Given this list of marker genes GDF15, BAX (BCL2 associated X, apoptosis regulator), B4GALT1, DDIT3, NUPR1 (NCBI Gene Id 26471), HYOU1, here is a description of the gene set: Genes down-regulated in synovial sarcoma samples with SYT-SSX fusions resulting from translocation of SS18 to one of the SSX genes. Chromosomal translocations are frequently associated with soft-tissue sarcomas. Fusion proteins generated by such translocations often play critical roles in tumorigenesis. Therefore, it is important to understand the function of the fusion protein to develop therapeutic interventions. The t(X;18)(p11.2;q11.2) translocation found in synovial sarcomas results in a fusion between the SYT gene on chromosome 18 and an SSX gene on the X chromosome. Although SYT-SSX fusion proteins appear to trigger synovial sarcoma development, little is known about the downstream targets of SYT-SSX. We found that the SYT-SSX fusion protein produces a dominant-negative function for SYT, which is a transcriptional coactivator. We then analyzed the gene expression profiles of SYT-SSX1-expressing HeLa cells using oligonucleotide microarrays and found that the SYT-SSX1 fusion protein directly down-regulated the expression of COM1, a regulator of cell proliferation. COM1 was found to be expressed at relatively low levels in synovial sarcoma tissues and cell lines. We then investigated the impact of conditional COM1 expression in the synovial sarcoma cell line. Increased COM1 expression resulted in induced apoptosis and in reduced cell growth and colony formation activity. Our results suggested that restoration of COM1 expression may be of therapeutic benefit in synovial sarcoma. Human Gene Set: ISHIDA_TARGETS_OF_SYT_SSX_FUSIONS species: Homo sapiens from publication Ishida M, Miyamoto M, Naitoh S, Tatsuda D, Hasegawa T, Nemoto T, Yokozeki H, Nishioka K, Matsukage A, Ohki M, Ohta T (PMID 17101797)